The following is a description of a gene set: Protein biosynthesis and ribosomes. studied in species Homo sapiens Human Gene Set: MODULE_114, and this is the list of marker genes: BEX1, RPL35A, EIF3E, CNPY2, RBCK1, RPL26, HPRT1, ZNF706 (zinc finger protein 706), RPS23, GSN, RPL10, MTPN, BCAP31, ZFAND6, PSMB7, UBA52, EIF4B, RPE, EIF3H, RPL18A, TIPIN, PYGL, UXT, ELOC, CANX, GRHPR, UCP2, MRPL21, SRSF7, RPL18, ATP5IF1, ARPC2, RPSA, NPM1, SNRPE, RBX1, ECPAS, PRDX6, METAP1, NCL, NDUFB1, COX7C, FKBP2, TAF7, RPL7A, PCBP1, RPL34 (NCBI Gene Id 6164), CCNDBP1, RPL39, PLTP, SNRPB, NDUFS5, SRP9, XPNPEP1, SOD1, GABARAP, NME4, SLC25A5, NDUFAB1, ATP5MC2, DAD1, MAGT1, DHRS7, RACK1, TMEM230, SCAND1, HINT1, NDUFAF7, ETFB, COMT, BST2, RPS13, TPT1, YWHAG, TPD52L2, PSMA6, RPL24, RPS19, STRAP, TSPYL1, RPS5, RPL31, RPS27 (NCBI Gene Id 6232), PHB2, FABP5, ATP5MJ, RPS21, ECI1, RPL4, SF3B5, RPL17, GTF2A2, ACAA1, UQCRB, RPL9, GNG10, NDUFA4, RAB11A, B2M, KRT24, PPIB, RPS16 (NCBI Gene Id 6217), RPS24, IL2RG, KHDRBS1, CSNK2B, RPS20, EDRF1, RPL8, EIF3G, EEF1D, ACADM, RPLP1, MRPL33, INHBB, BLOC1S1, EIF3F, PFDN5, GPX1, DYNLL1, TMEM147, LDHA, PTMA, RPS4X, RPS3, DDX3Y, RAB10, STAU1, ATP5ME, TRA2B, UQCRH, GAA, UBL5, MAPKAPK3, ECH1, NDUFS4, IMP3, ARMT1, MNDA, SEMG2, RPL23, RCN2, C19orf53, KPNA4, SEC61B, NSA2 (NSA2 ribosome biogenesis factor), CIAO2A, RPS11, ARHGDIA, RPS4Y1, RPL21 (ribosomal protein L21), LBR, MRPS24, RPL36A, RSL24D1, PSMA4, RPL10A, SNRPG, TIMMDC1, EIF3M, DPP7, SNRPD2, PRELID1, RPL6, ALDH9A1, CHMP2A, GPX4, RPL27, CDC37, UQCR11, RPLP2 (NCBI Gene Id 6181), PRDX4 (peroxiredoxin 4), RPL36AL, HSPA8, DAP, CST7, COX6C, RPL23A, EXOSC4, ALDOA, IMPDH2, CBX6, VDAC1, ATP5PO, SDHB, RPS25, PKM, RRP9, AP2S1, PLAAT3, MSI1, NDUFA1, HSBP1, DPY30, TMSB4X, RPL27A, PSMD10, ARPC3, LGALS3, HLA-C, EIF3I, MGST1, RPL7, CES1, FUCA1, PFN1, SNRPB2, EIF3K, CPQ, RPS10, LRPPRC, NDUFA13, FDPS, CARD19, RPL15, TPRKB, ERP29, RPS2, HSPB1, MFSD1, PNP, RPS27L, EEF1G, CHPF, CLEC2B, SRSF2, APMAP, RNASEH2C, MYL6, COX7A2, RB1, UQCRQ, CIB1, SPG21, CLIC1, NACA, RPL35, MB, CD63, UQCRC2, ERRFI1, STMN1, MYL12B, PSMA2, ZFP36L1, PSMB4, NME2, RPS9, GABARAPL2, ZNF525 (zinc finger protein 525), EIF1, YME1L1, EEF1B2, SSBP1, PSMD6, TGIF1, RPL12, PIH1D1, RPL19, CCT3, CDC40, RTRAF, ADIPOR2, HLA-A, NDUFB7, LBHD1, RPL11, WDR83OS, PRDX1, RPL38, HIGD2A, CNIH1, RPL14, PPA1, SNRPC, ATP5PF, RPL13A, PSMB1, ATP5F1B, CTSC, RPS15A, LSM3, RPL32, LSM5, CAPNS1 (NCBI Gene Id 826), EXOSC7, MDH1, CCT8, BTF3, RPS28, ABCC1 (NCBI Gene Id 8133), PSMD8, NAP1L1, ATP5MC3, LYZ, RPL29, RPL13, TPI1, COX6B1, GYG1, P4HB, PCNA, COX7B (cytochrome c oxidase subunit 7B), PABPC1, UQCRFS1, TMEM59, AIF1, MACROH2A1, RPLP0, NDUFV2, RPS3A, RAMAC, OAT, COX5B, ELOB, ATP6V0E1, ZNHIT1, ATP6V0B (ATPase H+ transporting V0 subunit b), RPS27A, RHOG, RPL28, M6PR, PLP2, EEF2, CYBA, SRGN, GADD45G, APRT, ATP5MF, ARPC1B, MRPS18B, EEF1A1, FAU, RAD23A, EIF4A1, ZNF451, VBP1, SNX6